Given this list of marker genes Gm13276, Oas2, Ifna6, Ifna13, Ifna7, Oas1a, Irgm2 (NCBI Gene Id 54396), Ythdf3 (NCBI Gene Id 71600), Isg15, Irf1, Mavs, Usp27x, Ifna5, Rbm47, Irgm1, Mettl3, Stat2, Lsm14a, Usp18, Oas3, Mmp12, Hpx, Stat1 (signal transducer and activator of transcription 1), Nlrc5 (NLR family, CARD domain containing 5), Gpr108, Irf3, Otop1, Ifitm3, Trex1, Ttll12, Trim41, Oas1c, Parp14, Sting1, Trim65, Gm13277, Oas1g, Dcst1, Gm13275, Trp53, Ifnab, Hdac4, Oas1d, Ifna15, Ifna14, Ifitm7, Ythdf2, Trim56, Eif4e2, Wnt5a, Ifnar1, Med1, Ifna11, Oas1e, Gm13271, Ptpn2, Ifngr2, Ifnz, Ikbke, Usp29 (ubiquitin specific peptidase 29), Oasl2, Ifnb1, Mul1, Oas1b (2'-5' oligoadenylate synthetase 1B), Txk, Ifnar2, Ifne, Gigyf2, Arg1, Ifngr1, Adar, Ifitm2, Ube2k, Sin3a, Ifng, Irf7 (NCBI Gene Id 54123), Pparg, Ifna4, Jak2, Ifih1, Ifnk, Cactin, Oasl1, Samhd1, Ifna1, Ifna9, Ifitm1, Irak1, Cdc37, Rnf185, Ifna16, Igtp, Gm13283, Ifna12, Parp9, Dnaja3, Tbk1, Oas1h, Epg5, Gm13272, Jak1, Fadd, Tyk2, Ifitm6, Myd88, Trim6, Oas1f, Smim30, Ifna2, Cnot7, Zbp1, here is a description of the gene set: The series of molecular signals initiated by type II interferon binding to its receptor on the surface of a target cell, and ending with the regulation of a downstream cellular process, e.g. transcription. Type II interferon is also known as interferon-gamma. species: Mus musculus Mouse Gene Set: GOBP_INTERFERON_MEDIATED_SIGNALING_PATHWAY